Given this list of marker genes CHD5, MAGEL2, HTR2A, CNTNAP2, SLC6A4, KMT2E, SNRPN, SIM1, NDN, OCA2, HDAC4, USP7, here is a description of the gene set: studied in species Homo sapiens Skin-picking Human Gene Set: HP_SKIN_PICKING Repetitive and compulsive picking of skin which results in tissue damage.